The following is a description of a gene set: species: Mus musculus Mouse Gene Set: GOBP_CALCIUM_DEPENDENT_CELL_CELL_ADHESION_VIA_PLASMA_MEMBRANE_CELL_ADHESION_MOLECULES The attachment of one cell to another cell via adhesion molecules that require the presence of calcium for the interaction., and this is the list of marker genes: Cdh7 (cadherin 7, type 2), Nlgn1, Sell, Cdh24, Arvcf (NCBI Gene Id 11877), Cdh9, Cdh2, Cdhr18, Cdh6 (cadherin 6), Pcdh1, Pcdh18, Cdh4, Ajuba (NCBI Gene Id 16475), Cdh3, Cdh8, Cdh26, Pcdh12, Cdh22, Cdh1, Cdh16 (cadherin 16), Cdh15, Cdh17, Selp, Cdh12, Cdh20, Cdh10, Pcdhga12, Cdh5, Nrxn1, Cdh11, Atp2c1, Cdh18, Pcdhgc3, Cdh23, Cdh19, Kifap3, Cdh13